Given this list of marker genes SNRPE, RPS2, HPN, HAX1, COX6A1, CRABP2 (cellular retinoic acid binding protein 2), LCN2, DPP7, SPP1, KRT6C, TFF1, SFN, RPL27A, APRT, RPS5, RAN, RPL7, LDHB, COL11A1, MIF, IGKC, NME1, HSPD1, HSPB1, PTPRF, MMP12, YWHAZ, TKT, LTF, LDHA, PSMD8, CLDN9, RAB1A, KPNA4, ERBB3 (erb-b2 receptor tyrosine kinase 3), DENND2B, RPL10A, YWHAQ, RPS16, COL1A2, HSP90B1, S100P, RPL17, PDCD6, ATP1B1, PSMB4, STAT1, MAGED1, RPL38, KRT5, GPI, EEF1D, VEGFA, RPL36A, PFN2, RPS21, P4HB, ASCL1, SDHA, RPL28, NQO1, SCNN1A, PRDX1, FGB, UQCRH, YIF1A, DAP, RPS27, NTS, SUMO2, TRIM28, TRIM2, TALDO1, TIMP1, PLPP2, SNRPD2, UBE2C, CYCS, RPL31, CDH1, IGFBP2, AKR1A1, THBS2, LAPTM4B, MARCKSL1, FSCN1, ERBB2 (NCBI Gene Id 2064), AKR1B10, MSLN, RPL37A, CEACAM5, MCL1, SPINT1, DDOST, SLC22A18, CRH, CALR, MDK (NCBI Gene Id 4192), CD46, NME4, KRT7, CSTB, NACA, SSR4, PGD, TOP1, HYOU1, PABPC1, RPS4X, RPS10, GFUS, IGFBP3, ADGRG1, MALL, ABCC3, XBP1, PKM, UGDH, TFF3, ENC1, AKR1C1, ATP5MF, SYNGR2, EIF3C, CANX, PLP2, UQCRB, JTB, UCHL1 (ubiquitin C-terminal hydrolase L1), ARL6IP1, ELOC, ZNF146, SPINK1, RPL8, DSP, TXNRD1, LGALS3BP, TUFM, UBE2I, RPL27, SLC7A5, MUC1, HDGF (heparin binding growth factor), POSTN, TSPAN8, GALNS, CCT3, PRDX4, COL1A1, RPL37, TRAF4, CBX3, JUP, CHIT1, RPL35, HSPE1, KDELR1, PHLDA2, SPINT2, RPL30, ALDOA, SOX4, GIPR, FGG, CDK2AP2, RPL13, CKAP4, RPS7, RPL23A, NME2, BGN, RPS20, CCT5, ENO1, HSPA5, PLAU, EEF1A2 (NCBI Gene Id 6669), PFKP, CEACAM6, SYN1, CLDN4, IDH2, ODC1, here is a description of the gene set: Genes with increased copy number that correlates with increased expression across six different lung adenocarcinoma cell lines. from publication Li R, Wang H, Bekele BN, Yin Z, Caraway NP, Katz RL, Stass SA, Jiang F (PMID 16369491) Amplification and overexpression of putative oncogenes confer growth advantages for tumor development. We used a functional genomic approach that integrated simultaneous genomic and transcript microarray, proteomics, and tissue microarray analyses to directly identify putative oncogenes in lung adenocarcinoma. We first identified genes with increases in both genomic copy number and transcript in six lung adenocarcinoma cell lines. Next, we used two-dimensional polyacrylamide gel electrophoresis and mass spectrometry to identify 42 proteins that were overexpressed in the cancer cells relative to normal cells. Comparing the genes with the 42 proteins, we identified four genes - PRDX1, EEF1A2, CALR, and KCIP-1 - in which elevated protein expression correlated with both increased DNA copy number and increased transcript levels (all r > 0.84, two-sided P < 0.05). These findings were validated by Southern, Northern, and Western blotting. Specific inhibition of EEF1A2 and KCIP-1 expression with siRNA in the four cell lines tested suppressed proliferation and induced apoptosis. Parallel fluorescence in situ hybridization and immunohistochemical analyses of EEF1A2 and KCIP-1 in tissue microarrays from patients with lung adenocarcinoma showed that gene amplification was associated with high protein expression for both genes and that protein overexpression was related to tumor grade, disease stage, Ki-67 expression, and a shorter survival of patients. The amplification of EEF1A2 and KCIP-1 and the presence of overexpressed protein in tumor samples strongly suggest that these genes could be oncogenes and hence potential targets for diagnosis and therapy in lung adenocarcinoma. species: Homo sapiens Human Gene Set: LI_AMPLIFIED_IN_LUNG_CANCER